Given this list of marker genes ATP4B, DNAJA2, DNAJB1, HSCB, DNAJA1, DNAJB4, DNAJB6, BRSK2, ATP6AP1, FXYD2, SIL1, HSPA4L, HYOU1, GTF2H4, DNAJC24, CCAR2, ATP1B2, KATNB1, BAG4, BAG5, FNIP2, DNAJB2, FNIP1, AHSA2P, DNAJC2, NKRF, TOR1AIP1, MYBPC3, BAG2, ATP5IF1, GRPEL2, DNAJC15, DNAJC19, PFN1, HSPBP1, DNAJC1, HSPH1, HDAC6, DNAJC10, BAG1, AHSA1, ATP1B3, HSPA4, ATP1B1, DNAJC7, TOR1AIP2, BAG3, TSC1 (NCBI Gene Id 7248), GRPEL1, PLN, here is a description of the gene set: species: Homo sapiens Human Gene Set: GOMF_ATPASE_REGULATOR_ACTIVITY Binds to and modulates the activity of an ATP hydrolysis activity.